The following is a description of a gene set: Human Gene Set: HOLLEMAN_PREDNISOLONE_RESISTANCE_ALL_UP Genes distinguishing prednisolone resistant and sensitive ALL (B- and T-lineage ALL); here - genes up-regulated in the drug resistant samples. from publication Holleman A, Cheok MH, den Boer ML, Yang W, Veerman AJ, Kazemier KM, Pei D, Cheng C, Pui CH, Relling MV, Janka-Schaub GE, Pieters R, Evans WE (PMID 15295046) species: Homo sapiens Childhood acute lymphoblastic leukemia (ALL) is curable with chemotherapy in approximately 80 percent of patients. However, the cause of treatment failure in the remaining 20 percent of patients is largely unknown., and this is the list of marker genes: TIMM17A, SMARCB1, NTAN1, POLDIP3, TLE5, HRK, U2AF2, TAF5, MED28, SUMO2, MAGOH, CRKL, PCBP1 (poly(rC) binding protein 1), F8A1, HNRNPR, PHF2, HNRNPUL1, ZNF318, OTUB1, TMEM131L